The following is a description of a gene set: studied in species Homo sapiens from publication Yevshin I, Sharipov R, Kolmykov S, Kondrakhin Y, Kolpakov F (PMID 30445619) Genes containing one or more binding sites for (DLX6) in their promoter regions (TSS -1000,+100 bp) as identified by GTRD version 20.06 ChIP-seq harmonization. Human Gene Set: DLX6_TARGET_GENES, and this is the list of marker genes: S100P, NUDT5, MRPL27, IMMP1LP1, CUL5, MTTP, COQ7-DT (NCBI Gene Id 102723385), HAX1, GET3, ULK3, PPP5D1P, EMC4, H4C13, DANCR, RETREG2, ARRDC3, TIMM13, KBTBD2, STAM-DT, MAPKAPK5, SLC3A2, ZSCAN5A-AS1, NDC1 (NCBI Gene Id 55706), CDC123, ZNF436-AS1, CSNK2A1 (casein kinase 2 alpha 1), ADCY9, CAMKMT, SNORA84, OPLAH, REV3L, TPI1P2 (triosephosphate isomerase 1 pseudogene 2), YIPF3, SLC16A5, MTIF2, ING3, MRPS33, TMEM267 (transmembrane protein 267), GOT1-DT, ALDH2, HDGF (NCBI Gene Id 92300), STYXL1, ZNF131, ADAMTSL4-AS1, AHSA1, MPDU1, MRRF, HOXB9, DEDD, ALKBH1, SNHG11, DDX39B (DExD-box helicase 39B), ZNF143, IDH3A, KIF2C, ARPC5L, COPS5, PAAF1, TFPT, LINC02889, PPP1R14B, PSME3, PLA2G6, RPL19, MCCC2, CAPG, PRCC, RPS23, RXFP4 (NCBI Gene Id 79359), FMC1-LUC7L2, AARS1, CNOT1, HOXA10-AS, PMEL, ETS2-AS1, CHASERR, GSAP, OXA1L, SH3RF2, MIR4258, TAF1D, FPGS, ACAD9, PPP2R3C, SREK1IP1 (NCBI Gene Id 285672), FAM219B, JMY, PPFIBP2, SNX8, SRRM2, MRPL46, NIFK-AS1, TNFAIP8, CCAT2, ATP6V1G2, MIR22HG, ZNF574, KRT8, SHMT2, GPR19, SRP54-AS1, CNOT2, HOXA11-AS, TFAP2A, ZMYND8, KNL1, RPS18, SP1, SUPT4H1, FARSB (NCBI Gene Id 112957), ATPSCKMT, DNAJA3, LINC02960, GTPBP2, MKLN1 (NCBI Gene Id 55782), PRDM10, ATP6V1A, USP16 (ubiquitin specific peptidase 16), INAVA, SMIM14-DT, UBE3A, SFXN4, THRAP3, SRSF10, EHD1, LINC00910, FEN1, WDR25 (NCBI Gene Id 79446), CFAP92, SHLD3, PRKCI, ZNF786, KPNB1, PDAP1, ACY3, HMGCR, KLF6 (KLF transcription factor 6), SEPTIN9, DCAF17, GTF2IRD1, B3GALT5-AS1, SLC7A11, ZNF436, ATP6V1G1, GOLPH3, CCPG1, ENSG00000273162, PDP2, CDHR2, PRELID3B, OGFOD2, TM9SF4, ELOB, VIPAS39, RACK1, ZDHHC6, MAML3, ENSG00000234162, DNAJC7, ZNF770, AP5Z1, DELE1, SLC38A1, COG4, RNA5SP396, RAD50, METTL4, GPRC5A, TRAPPC13, GHITM, TRMT12, BNIP2, SHC1, ENTPD1-AS1 (NCBI Gene Id 79267), ID1, EDC3, DMTF1-AS1, SAE1, POLR1G, HKDC1, SNHG8, PIERCE2, MPDU1-AS1, RPN1, ENSG00000268460, SRD5A1, GPA33, DAZAP2, SNORA73A, WARS2-AS1, NDUFA4, CSPP1, CNPY2-AS1, LINC02453, NEMP2-DT, LINC02363, ZNF692, LARS1, ABHD11, PTGES3, H2BC16P, MIR141, LNCATV (lncRNA negative regulator of antiviral signaling), ZNF292, ARHGEF2, NOP16, LTBR, HMGB1, ATP6V1E2 (ATPase H+ transporting V1 subunit E2), TBX6, STK35, FER, MYL11, SCARB1, CALM3, METTL8, TRMT10A, VPS50, SNORA80D, CCNB1, MIR3651, RETREG1, SPAG9, H2AC16, MRPL54, CDK4, TRIM23, EIF6, CTDP1, SNORA3A (small nucleolar RNA, H/ACA box 3A), IFT70B, MSH5, PCBP1, RHOC, RFX3, BISPR, UQCRQ, THAP6, TMEM44-AS1, XPOT, CEP120, GART, DDX39B-AS1, RHBDF1, SNORD48, C19orf33, RBM3, TRMO, CFAP107, KIAA0319L, NAA50, DNAAF5, SNHG32, RPL30, STAT6, H2AC6, G3BP2, HOXC-AS2, STK40, ANAPC7, CISD3, TTC7A, NCDN, ICA1-AS1, MPG (N-methylpurine DNA glycosylase), ZNF398, PIGBOS1, MRPS11, CCDC9B, NAPEPLD, EHF, KPTN, SAMD13, SNORD25, GOLGA3, PRPF31, AP1AR (adaptor related protein complex 1 associated regulatory protein), SERF2, C17orf49, RBM22, ARHGEF2-AS2, SON, MIR200C, CS, GPANK1, R3HDML-AS1, TRAF3IP2-AS1, CSNK2B, SCARB2, MGAT1 (NCBI Gene Id 4245), MTPAP, RNF6, ATP6AP1L, MAIP1, RPL7L1, RPS27A, RHBDD1, NOD1, DLGAP1-AS2, CMBL, CBR1, SH2D6, SNORD46, CENPP, RBBP5, CAPZA1, H2BC10, CLDN12, PAN2, UNK, BECN1, HOXA11, SPINK6, FAM174C, SIK3, PCBP1-AS1, CYP1B1-AS1, ZNF48, CDKN1B, GNPDA1, KHDC4, SEC24C, SEPHS2, GTF2A1-AS1, PPP1R15A, SFSWAP (splicing factor SWAP), PSMB5, BST2, ZNF133, ZDHHC5, PLOD3, RIC8B, TTI1, THADA, RNF13, DHFR, LDLR, STAM, SNORD28, GPAM, VSNL1, RNY1P8, HEXA, BANP, IL5, STX10, RNU4-86P (NCBI Gene Id 106481199), CDC42EP4, CALML4, SNHG1, BUD31, PSMD7 (NCBI Gene Id 5713), STX4, RBM47, PPP1R13L, DDX5, TYW5, PRORP, SMIM15, ALDH1A2, VTI1A, SNORA24, CRYBG2, RTF1, H3-3B, WARS2, PAIP2, HNRNPA2B1, NSL1, PREPL, H3C8, MIR4320, EXD2, VASP, SRRT, PEAK1, RIOK2, DAGLB, EARS2, ZNF692-DT, CWC27, RPL41, ARMH4, RAB30, KAZALD1, NEDD8, ATG101, EME1, WDR74, SNRPA, USF1, PRLR, UNC13D, NEMP2, DDX3X, APBB3, LBX2, TMEM54, INO80E, RPS12, EIF3B, EFNA1, MRPS15, C2orf88, RALA, UBFD1, TMCO4 (transmembrane and coiled-coil domains 4), AKAP9, LRRC41, TMEM268, GTF2I, UEVLD, FEM1A, BCL3, SNORD26, LINC-PINT, ARID4A, FAF2, ARRDC3-AS1, CKS1B, KCTD21-AS1, NDC80, NEMF, CAND1, HYAL3, CEP95, RPS8 (ribosomal protein S8), RHOQ, CDC42SE1, FAM13A, MALAT1, ZAR1L, PTCD2, ST7L, HNF4A (NCBI Gene Id 4339), SF3B3, ATG4C, MAP1LC3B, RPL32, PIGB, AP2B1, NEK9, TMEM258, RBM39, CXCL2, AFG1L, SLMAP, RPS14, WDR5B, S100A2, RPL27A (ribosomal protein L27a), MED24, NDUFB8, HM13-AS1, OXSR1, WARS1, RNU5D-1, SRRM2-AS1, CSRP1, ACTMAP, SNORD27, HIRIP3, IL23A, HOXA3 (homeobox A3), SLC25A6, CLIC1, ZNF343, FTSJ3, LINC02026, CLASP1, P2RX4, BRD9, PDCD4, TXNDC15, CBR4-DT, TPM1, CLDN7, PSMA5, TRIP13, SECISBP2, MIR200CHG, NBR1, PPP1R1B, LRPPRC, SNORA26, IGHV3-19, UQCRC2, HINT1, PPP1R14B-AS1, ZMYM6, TATDN3, ALG2 (ALG2 alpha-1,3/1,6-mannosyltransferase), VTRNA1-1 (NCBI Gene Id 56664), COQ7, NOL8, SNORD35B, SKP1, CITED2, SETD1A, GMPR2, ZBTB8OS, FTH1, BRCA1, YARS2, ASF1B, CCDC28A-AS1, TNPO3, ZNF341-AS1, SMIM14, CBR4, SH2D3A, RNH1, NSUN2, COASY, ABCB9, ATXN2L, NAGLU, UQCRH, FBXL19, GSPT1, CBX3, NAPA-AS1, LINC02688, PSMA3-AS1, CNPPD1, HERPUD1, NOP56, RFX3-DT, TRIB3, ALG8, ZSCAN5A, PSIP1, SEC24A, RRAS, OSBP, WSB2, ZNHIT1, FADS2, COX7A2L (cytochrome c oxidase subunit 7A2 like), LAMB3, USP3, PSAT1, PRDM10-DT, ENSG00000243081, PHLDA2, CNTD1, PTMA, NXPE2, USP54, CCDC124, SNAP23, CHD1, SEC61B, UBR2, TDO2, SRP54, TM9SF1, NAA80, PDIK1L, TMED10, SLC35A4, IBTK, RBBP4, NEDD8-MDP1, AFG2B, FAM98B, ENSG00000266401, CMSS1, UPF2, CPEB4, FAM83C-AS1, ENO1, BRCA2, G3BP1, PYROXD1, SCAF1, NDUFA5, SNORD95, SF3B6, PSMC5, CLHC1, DNAJC27-AS1, DSN1, ZBTB7C, HDAC1, SLC44A3-AS1, ATP6V1G2-DDX39B, CCDC28A, FMC1, MVB12A, MEGF11 (multiple EGF like domains 11), RAB30-DT, LINC02313 (long intergenic non-protein coding RNA 2313), HMG20A (high mobility group 20A), RPL6, TBC1D1, RAB27A, NFKBIL1, TFF2, RPL22, ESRP2, MIR4512, TRIM31, UCA1-AS1, SP100, GTF2A1, SPATA24